Given this list of marker genes Isg20, Rnf213, Sp100, Oas3, Lgals3bp, Ifit3, Ccnd2, Isg15, Ifi203 (NCBI Gene Id 15950), Samd9l, Psmb8, Ifit1, Mndal, Ms4a4b, Usp18, Trim12c (NCBI Gene Id 319236), Stat1 (signal transducer and activator of transcription 1), Parp14, Trim30a, Psmb10 (NCBI Gene Id 19171), Zbp1, Slfn1, Ifi27l2a, Oasl2, Bst2, Ifi35, Irf7, Trim12a, Ifi47, Xaf1, Parp9, Epsti1, Ly6e, Ifi206, Slfn8, Herc6, Trim25, Irf9, Plac8 (placenta-specific 8), H2-T23, Slfn5, Rtp4, here is a description of the gene set: Cytokines mediate cell-cell communication in the immune system and represent important therapeutic targets. A myriad of studies have highlighted their central role in immune function, yet we lack a global view of the cellular responses of each immune cell type to each cytokine. To address this gap, the authors created the Immune Dictionary, a compendium of single-cell transcriptomic profiles of more than 17 immune cell types in response to each of 86 cytokines (>1,400 cytokine-cell type combinations) in mouse lymph nodes in vivo. A cytokine-centric view of the dictionary revealed that most cytokines induce highly cell-type-specific responses. For example, the inflammatory cytokine interleukin-1β induces distinct gene programmes in almost every cell type. A cell-type-centric view of the dictionary identified more than 66 cytokine-driven cellular polarization states across immune cell types, including previously uncharacterized states such as an interleukin-18-induced polyfunctional natural killer cell state. Mouse Gene Set: CUI_T_CELL_CD8_IFNE_RESPONSE_UP Genes positively differentially expressed in cell type: CD8+ T cell upon treatment with cytokine: IFN-ε in mouse lymph nodes in vivo. from publication Cui A, Huang T, Li S, Ma A, Pérez JL, Sander C, Keskin DB, Wu CJ, Fraenkel E, Hacohen N (PMID 38057668) species: Mus musculus